The following is a description of a gene set: Mouse Gene Set: REACTOME_SYNTHESIS_OF_12_EICOSATETRAENOIC_ACID_DERIVATIVES species: Mus musculus Synthesis of 12-eicosatetraenoic acid derivatives, and this is the list of marker genes: Alox15, Alox12, Alox12b, Gpx1, Aloxe3, Gpx2, Gpx4